The following is a description of a gene set: Human Gene Set: GOBP_POSITIVE_REGULATION_OF_NATURAL_KILLER_CELL_ACTIVATION species: Homo sapiens Any process that activates or increases the frequency, rate or extent of natural killer cell activation., and this is the list of marker genes: ZBTB1, HLA-E, BLOC1S3 (biogenesis of lysosomal organelles complex 1 subunit 3), STAT5A, TYROBP, IL12A, IL12B, STAT5B, IL15RA, GAS6, TOX, TICAM1, AXL, MIR130A, IL23A, IL23R, RPL13A, FCGR3A, RASGRP1, JAK2, IL21, BLOC1S6, FLT3LG, TYK2, IL18 (NCBI Gene Id 3606), IL15